The following is a description of a gene set: from publication Motenko H, Neuhauser SB, O'Keefe M, Richardson JE (PMID 26092688) Mouse genes annotated to increased adenoma incidence (MP:0010383) retrieved from the Mouse Genome Informatics database via MouseMine Mouse Gene Set: MP_INCREASED_ADENOMA_INCIDENCE species: Mus musculus, and this is the list of marker genes: Kras, Tom1l2, Rassf1, Errfi1 (ERBB receptor feedback inhibitor 1), Tsc2, Pole, Brip1, Nkx2-1, Exo1, Kcne2, Sptbn1, Mlh1, Mcm9, Ssbp2, Il6st, Myc, Stk11, Atm, Dclre1a, Tff1, Trp53, Fancd2, Kitl, Apc, Fancf, Prdx1, Mus81